Given this list of marker genes BBS4, CATSPER1, GAS2L2, CFAP20, MKKS, TTLL6, BBS2 (NCBI Gene Id 583), CFAP45, BBS1, here is a description of the gene set: species: Homo sapiens Any process that modulates the frequency of cilium beating involved in ciliary motility. Human Gene Set: GOBP_REGULATION_OF_CILIUM_BEAT_FREQUENCY_INVOLVED_IN_CILIARY_MOTILITY